Given this list of marker genes MYOG, NLN, MAML1, NOTCH1, MTOR, CYP26B1, MAMSTR, XBP1, MYOD1, MIR200B, CAV3, MIR206, DMPK, SHOX2, MYF6, LMOD3 (leiomodin 3), MMP14, PIEZO1, NACA, BCL2, ATP11A, HDAC1, BDNF, ACTN3, BHLHE41, SIK1, PLPP7, HDAC3, HDAC9, NKX2-5, FBXO22 (NCBI Gene Id 80234), TRIM72, MYOCD, MIR133A1 (NCBI Gene Id 406922), MIR1-1, SMYD1, BHLHA15 (basic helix-loop-helix family member a15), HDAC4, MAPK14, RBM38, MYF5, RPL3L, CEACAM5, HDAC5, TBX1, RBM24 (NCBI Gene Id 221662), TMEM119, CCN3, MIR133B, here is a description of the gene set: studied in species Homo sapiens Human Gene Set: GOBP_REGULATION_OF_MYOTUBE_DIFFERENTIATION Any process that modulates the frequency, rate or extent of myotube differentiation. Myotube differentiation is the process in which a relatively unspecialized cell acquires specialized features of a myotube cell. Myotubes are multinucleated cells that are formed when proliferating myoblasts exit the cell cycle, differentiate and fuse.